The following is a description of a gene set: Human Gene Set: OCT1_Q5_01 Genes having at least one occurrence of the motif TNATTTGCATW in the regions spanning 4 kb centered on their transcription starting sites. This matches the POU2F1 transcription factor binding site V$OCT1_Q5_01 (v7.4 TRANSFAC). species: Homo sapiens, and this is the list of marker genes: NOS1, PATZ1, LPL, FOXP2, SERTAD4, CNNM4, LMO3, GRIA3, SMPX, GPR85, SFRP2, HNF1B, NPHP4, DLGAP4, SH3BGRL, OTX2, ZNF428, PCDH11X, EAF2, PHF6 (PHD finger protein 6), CSRNP3, FGF20, IGSF21, PIGT, CLCA3P, PPP2R5C, HOXB4, FBXO24, ALDH1A1, FOXP1, ADORA1, ANXA2, FGF14, ROGDI, ZC3H14, ADORA2A, TP53INP2, TRAF3IP2, ZFC3H1 (zinc finger C3H1-type containing), NFIA (nuclear factor I A), GPRC5B, MTUS1, IRX4, EYA1, MAB21L2, BCL2, RANBP3L, MID1, H2AC12, SP6, PRICKLE2, ARF6, SLC25A35, TMSB4XP4, CCDC116, PHOX2B, GAB2, SPRR2B, NRXN3, CADM1, C10orf71, H2AC20, DLG2, MPPED2, KCNN3, PTHLH, CSRNP1, CD180 (CD180 molecule), H2AC4, SKIDA1, SCOC, PRRC2A, CTAGE4, VPREB3, VSNL1, BLNK, RPP21, RCAN1, BRINP3, HOXA10, SLC6A15, NXPH1, UPK3A, SLITRK6, FSTL5 (follistatin like 5), NDP, TCP11L2, H3C3, JUND, H3C2, NEUROG1, PLPPR2, KRTAP8-1, NSMCE3, CADM2, KANSL1L, H2BC1, CCN1, TSPAN13, PCYT2, SRF, HOXC11, ATP2A2, PCDH11Y, HOXB6, VGLL3, TCERG1L, PDE4D, ATP8B1, POU2F3, RXFP1, CBFA2T2, WNT6, OR8B8, CSF3, ADNP2, MRAS, REL, SLC25A12, SRSF2, TPD52, TLL2 (tolloid like 2), RAB26, MMP1, H2AC14, SEMA6C, ARMCX4, EDA, ARHGAP4, TMOD2, CDX2, H2BC4, HOXD11, LYN, TTI2, SUCNR1, TMSB4XP6, BCORP1, PPP2R2B, MGAT5B, FZD4, ALK (NCBI Gene Id 238), E2F3, HPCAL4, OPA3, TMCC1, KBTBD12, MED16, ARMC6, NIN, RTTN, HOXB8, ISL1, FCHSD1, TAS2R40, TAS2R13, GALNT1, PRDM1, SPTY2D1, LIPG (NCBI Gene Id 9388), KIF13A, PFKFB1 (6-phosphofructo-2-kinase/fructose-2,6-biphosphatase 1), UQCC2, H2AC6, ETV1, RRAS, CXXC4, IL25 (NCBI Gene Id 64806), ASCL3, LINC00649, CDK2, PCDH8, DMD, BDNF, TRAF3, RDH11, STAT4, DPYSL3, PCYT1B, NRXN1, H3-3B (NCBI Gene Id 3021), ITSN1, TMSB4XP8 (TMSB4X pseudogene 8), OR10A5, ZNF362, SYNPR, SH3GL3, CES5A, C2CD5, TBXAS1, TCEAL1 (NCBI Gene Id 96422), SCML4, HOXD8 (NCBI Gene Id 56182), SYVN1, FAM117A, DUSP6, ZNF423, MYBPC1, TSC22D3, LRRN1, NRL, DLX1, THRA (NCBI Gene Id 7067), LRCH4, AMER1, GRHL3, RHOB, EGR2, MAP2K6, COL25A1, CEP41, H2BC12, CDX4, TRERF1, DAPK3, SFRP1, TCF12, PMEL, SUGP2, ITPRIP, NFYB, APOBEC4, CRACR2B, ZHX2, ATF7IP, CD86, CD40LG (NCBI Gene Id 959), HOXB3, HOXA5 (homeobox A5), MSI2, BTK, H2AC1, ASIC2, EBF1 (NCBI Gene Id 1879), GPM6A, SEC22A, LHX6 (NCBI Gene Id 26468), DIS3L, PLA1A, CDH10, POU3F4, TSNAX, THAP2, CRYZL1, PRRX1, SREBF2, CRISP1, H2BC14, RARB, ZSCAN20, EHF, TSPYL2, LDB2, CLRN1, PTEN, IQCB1 (IQ motif containing B1), C12orf57, DPYSL2, GPR4, PROKR2, UBE2S, GNA14, HOXA7, HOXC5, PPP2R3A, MANF, FOXG1, ODAPH, H2BC3, LCOR, NRAS (NCBI Gene Id 4893), STX12, FGF12, PIM2, PAX6